The following is a description of a gene set: studied in species Mus musculus Mouse Gene Set: GOCC_MHC_CLASS_IB_PROTEIN_COMPLEX A transmembrane protein complex composed of a MHC class Ib alpha chain and, in most cases, an invariant beta2-microglobin chain, and with or without a bound peptide or lipid antigen. Class Ib here refers to non-classical class I molecules, such as those of the CD1 or HLA-E gene families., and this is the list of marker genes: H2-M10.3, H2-T3, H2-Q2, H2-T10, H2-M10.1, H2-M10.4, H2-Q4, H2-M1, H2-Q1, H2-M9, H2-K1, H2-M10.2, H2-M10.5, H2-M11 (NCBI Gene Id 224754), H2-M2, H2-M3, H2-M10.6, H2-M5, H2-T23, H2-T22, H2-D1, H2-Q7 (histocompatibility 2, Q region locus 7), H2-Q6, H2-Q10